The following is a description of a gene set: Human Gene Set: GOBP_REGULATION_OF_CILIUM_BEAT_FREQUENCY Any process that modulates the frequency of cilium movement, the directed, self-propelled movement of a cilium. species: Homo sapiens, and this is the list of marker genes: BBS2, MKKS, CCDC39, GAS2L2, CATSPER1, CFAP20, BBS4, CCDC40, CFAP206, TTLL6, CFAP43, DNAAF1, CYB5D1, CFAP45, ODAD2, BBS1, DNAH11